Given this list of marker genes GNA15, ASIP, MLANA, PLCB2, TYRP1, ADCY2, SERPINF1, PRKCB, MC1R, GPR143, PLCB4, TYR, ADCY9, PRKACB, PRKACA, ITPR1, MITF, PMEL, DCT, ARRB2, ARRB1, PRKACG, VEGFA, CREB1, POMC, PLCB1, PLCB3, ADCY4, GNAQ, GNAS, here is a description of the gene set: Human Gene Set: WP_GPR143_IN_MELANOCYTES_AND_RETINAL_PIGMENT_EPITHELIUM_CELLS GPR143 in melanocytes and retinal pigment epithelium cells studied in species Homo sapiens